The following is a description of a gene set: studied in species Homo sapiens Human Gene Set: EGR3_01 Genes having at least one occurrence of the motif NTGCGTGGGCGK in the regions spanning 4 kb centered on their transcription starting sites. This matches the EGR3 transcription factor binding site V$EGR3_01 (v7.4 TRANSFAC)., and this is the list of marker genes: SEC14L1, TBC1D10A, PRR3, SRCIN1, NDUFA4L2, VEGFA, PDZD7, MRC2, ANKS1A, PDGFB, CSRNP1, SH3GL3, RBBP6, PABIR2, DYNLL1, CLTC, WNT1, YTHDF3, PNCK, HNRNPDL, SORCS3, SMYD5, MAN2A2, KREMEN2, MYB, TAF11, ERGIC3, VGF, FUS, EGR1, YME1L1, UBE2W, RALYL, SIRT1, IGF2BP1, KCNQ5, CMAS, HMGN2, PLPPR1, HMG20B (high mobility group 20B), WDR44, RANBP1, PDCD6IP, CELF4, SCN5A, ZCCHC14, XK, ETV4, ITGB8, PTPN7, EPHB1, POLR1G, USP4, HDAC9, BMPR2, RALGPS2, MASTL, EGR3, TSGA10, C9orf72, SRRM4, PTCHD1, SNAP25, PRKACA (protein kinase cAMP-activated catalytic subunit alpha), HRK, ATP8B2, TP53I11, C2orf15, ATP6V1C1, ERF, NOP53, CDKN2C, SSTR3, SUN2, GNL1, PCOLCE, TRMT2A, CD40LG, CGGBP1, GSX1, UBASH3B, KLF5, L1CAM